The following is a description of a gene set: Mouse Gene Set: GOBP_MONOATOMIC_CATION_TRANSPORT The directed movement of a monoatomic cation, into, out of or within a cell, or between cells, by means of some agent such as a transporter or pore. Monatomic cations (also called simple cations) are positively charged ions consisting of exactly one atom. studied in species Mus musculus, and this is the list of marker genes: Atp6v0a1, Kcnc3, Rem1, Trpv2, Selenon, Kcnn3, Slc22a1, Cacnb2, Tspan13, Steap4, Tspan18, Tmem74, Camk2b, Clca1, Slc25a23, Timd2, Kcnk13, Kcnd2 (NCBI Gene Id 97339), Atp6v1h, Slc45a4 (solute carrier family 45, member 4), Adora2a, Casq2, Atf4, Sphk2, Sik1, Abcb7, Cckar, Afg3l2, Ngf, Slc10a6, Ctss, Atp1b3, Drd3, Oprk1, Nipal4, Tmc2, Slc41a1, Akap9, Pcsk9 (proprotein convertase subtilisin/kexin type 9), Slc30a1, Slc6a8, Adora1, Sumo1 (small ubiquitin-like modifier 1), Heph, Rcvrn, Gas6 (growth arrest specific 6), Gal, Sting1, Dmpk, Letm1, Nkain3, Kcna6, Nkain1, Abcc2, Kcnip4 (Kv channel interacting protein 4), Trem2, Atp2b1, Trpc4, Slc12a5, Gja1, Abl1, Slc5a3, Cyba, Kcnf1, Trpc2, Pdgfrb, Grin2a, Plch1, Slc30a4, Slc6a18, Grm7, Plcb2, Slc39a7, Scara5, Cblif, Ednrb, Slc4a7, Tmco3, Lilra5, P2rx6, Gsto1, Otop2, mt-Nd5, Ubash3b, Cldn16, Slc25a5, Slc6a21, Slc6a11, Atp5mf, Kcnmb2, Tmx1, Atp4b, Slc12a7, Kcnab3, Trpa1, Slc6a7, Scn1a, Ndufa4, Nipal2, Oprd1, Slc6a19, B2m, Flvcr1, Kcnk10, Sestd1, Atp6v1g2, Steap2, Ccl21f, Fgf2, Slc9a9, Scnn1g, Slc47a2, Tmem37, Slc6a4, Asic5, Wnk4, Sec61a1, Gja4, Kcnt2, Kcnj14, Trdn, Casr, Nos1, Rab11b, Slc25a14, Nipal3, Cyc1, Slc10a5, Camk2g, Wfdc6a, Ucp1, P2rx7, Slc38a5, Hcn3, Plcb1, Scn4b, Slc36a3, Tusc3, Tmem63c, mt-Nd4, Akt3, Creb3, Slc12a3, Clec4b1, Atp6v1g1 (ATPase, H+ transporting, lysosomal V1 subunit G1), Ikbkb, Atp6v0b, Tcirg1, Adrb2, Zdhhc13, Adcyap1r1, Atp2b4, Abcb6 (NCBI Gene Id 74104), Large1, Slc17a2, Fxyd5, Hspa9, Cxcl12, Slc36a1, Slc17a6, Scn7a, Atp6ap1, Rhoa, Gck, Lyn, Flvcr2, Drd1, Atp6v1c2, Fkbp1b, Jph3, Kcnk12, Kcnip1 (NCBI Gene Id 72952), Plcl2, Uqcrfs1, 1810037I17Rik, Calm3, Otop1, F2, Pgrmc2, mt-Co1, Slc4a10, Ednra, Usp2, Cacng8, Abcc5, Ffar1, Slc9a4, Slc5a4b, Atp5f1b, Tmem163, Kcnq1, Catsper3, Slc8a2, Ccr5, Agt, Nppa (natriuretic peptide type A), Tmem94, Ccl19-ps5, Pkd1l1, Kcnq2 (potassium voltage-gated channel, subfamily Q, member 2), Ccl5, Grin2d, Atp2c1, Tfr2, Chrng, Kcna7, Tgfb2 (transforming growth factor, beta 2), Atp5mc1, Plcl1, Atp5pb, Kcnj6, Klhl3, Osr1, Trpm1, Slc41a2, Atp6v1a, Mmgt1, Cd19, Chp2, Ank3, Steap3, Cachd1, Selenok, Scnn1a, Catsper1, Slc4a8, Kif5b, Vmp1, Slc8a3, Il4, mt-Co3 (mitochondrially encoded cytochrome c oxidase III), Gnaq, Arrb2, Ace, Jph4, Slc5a4a, Cdkn1b, Ifng, Abcb8 (NCBI Gene Id 74610), Kcne2, Slc6a2, Atp6ap2, Fgf12, Gnb5, Hrc, Cacna1i, Slc39a5, Vamp2, Ppp3cc, Itgav, Gnao1, Slc1a3, Mllt6, Epo, Pdpk1, Surf1, Per1 (period circadian clock 1), Nfatc1, Pkd2 (polycystin 2, transient receptor potential cation channel), Slc23a2, Slc6a13, Scn3b, Cacna1b, Hsd3b6, Pacsin3, Tmco1, Commd9, Atp13a4, Inhca, Slc30a9 (NCBI Gene Id 76440), Kcng3, Cacnb4, Mcu, Micu2, Spg11, Ncs1, Slc25a13, Kcnk6, Cngb3, Nedd4l, Kcnn1, Mcub, Letm2, Kcnj5, Slc4a4, Ptger3, Htr2c, Ahcyl1, Slc39a14, Slc17a1, Atp1a2, Plch2, Tspo, Slc8a1, Fthl17e, Cacna1f, Tmem175, Slc25a28, Slc12a4, Ctnnb1, Ehd3, Dysf, Hamp2, Ptpn22, Dhrs7c, Pkd2l1, Wnt3a, Slc41a3, Htt, Ndufs2, Atp2c2, Romo1, Kcnn4, Rnasek, Gstm7, Abcc9, Kcnc2, Homer3, Nipal1, Slc6a20b (NCBI Gene Id 22599), Coa8, Slc22a4, Plp1, Hamp, Kcne5, Aplnr, Kcnc1, P2rx5, Chrna9, Slc38a11, Cx3cl1, Trpm6, Slc39a9, Lrrc38, Ctns, Slc20a1, Serpine2, Flna, Slc9c1, Cacna2d3, Nalf2, Cox4i2, Alg10b, Kcnk15, Homer1, Kcnma1, Fxn, Ank2, Kcnab2, Lrrc26, Ltf, Scn9a, Inpp5k, Gpr35, Myo1b, Atp5mc3, Vdac1, Cyp27b1, Cacng5, Grp, Hephl1, Hcn4, Calhm1, Rgs9, P2rx4, Nkx2-5, Slc48a1, Lpar3, Cd63, Lime1, Cbarp, Trpv4, Pml, Slc18a3, Mmp9, Kcnv1, Amigo1, Slc39a1, Cacna1e, Slc18b1, Mettl21c, Scnn1b, Trpc5, Slc18a2, Ptpn3, Kcnab1, Bdkrb1 (NCBI Gene Id 12061), Slc5a5, Kcnip3, Saraf, Cnga2, Tmc1, Kcng2, Atp7b, Otop3, Zmpste24, Scn8a, Tmem63b, Slc45a2, Slc25a25, Neto1, Slc30a5, Chrna1, Atp10d, Slc5a7, Plcb3, Slc30a8, Slc9a8, Slc17a7, Rgs4, Gpr39, Rgs7, Fxyd1, Asic3, Ptk2b, Orai1, Slc10a4, Ppp3cb (protein phosphatase 3, catalytic subunit, beta isoform), Orai3, Cngb1, Slc5a8, Tmem38a (NCBI Gene Id 74166), Cacng3, Adra1a, Kcnk18, Panx2, Calcrl, Nalf1, Slc15a1, Atp6v0e, Slc18a1, Stim1, Best1, Cacng4, Plcg2, Ppp3r1, Ramp3, Il6, Slc30a6, Wnk1, Slc5a12, Atp7a, Dspp, Slc24a4, Ndufs4, Nipa1, Slc39a12, Magt1, Slmap, Gcg, Cnksr3, Slc25a37, Ndufv1, Fmr1, Grm6, Commd3, Atp2a1, Slc4a11, Gimap5, Ryr3, Sri, Slc8b1, G6pd2, Slc15a4 (solute carrier family 15, member 4), Cdk2, Crh, Panx3, Scn10a, Prkcb, Cacnb3, Camk2a, Kcnrg, Mfsd4b1, Serpine1, Slc24a3, Atp6v0e2, Snta1, Slc31a1, Myo5a, Piezo1, Fkbp4, Oga, Atp5f1e, Epm2a, Kel, Pdgfb, Nol3, Camk2d, Srl, Micu3, Bhlha15, Ppp3r2, Akap5, Slc30a3, Hcn1, Trpm7, Gnb2, Edn1, Tmem63a, Tmem150c, Slc25a3, Atp1a3, Snx3, Mt3, Slc46a1, Fbxo11, Kcnk2, Kcns3, Cacna1d, Slc11a1, Kcnj8, Gnai2, Stac2, Atp13a3 (NCBI Gene Id 385637), Kcng4, Edn3, Atp12a, Stc1, Npsr1, Ccr1l1, Atp6v0d2, Mcur1, Ndfip1, Slc39a11, Hpn, Slc39a3, Trpv6, Gpm6a, Ucp3, Lrrc55, Ndufs3, Vps4b, Slc1a1, Cox7a1, Cxcl9, Tgfb1, Atp5f1a, Icam1, Psen1, Slc5a9, Capn3, Ccl19-ps4, Ano6, Slc12a2, Slc39a10, Smdt1, Nkain2 (Na+/K+ transporting ATPase interacting 2), Slc4a9, Slc11a2, Kcnj12 (NCBI Gene Id 16515), Atp5mc2, Chrne, Slc45a3, Slc38a3, Kcnj1, P2rx3, Trim27, Kcnq5, Ucn, Slc34a1, Cacna1a, Wfs1, P2rx1, Tcn2 (transcobalamin 2), Ccl21b, Hbp1, Ramp1, Atp5me, Kcnmb3, Slc45a1, Atp6v0d1, Steap1, Dpp10, Slc6a16, Trpm3, Cnga3, Slc6a3, Sfxn1 (sideroflexin 1), Slc39a13, P2ry12, Hpca, Il16, Kcnn2, Cav1, Gjc2, Kcnh2, Cacna1c, Cherp, Slc34a2, Isl1, Ubqln1, Cpox, Il13, Lrp2, Bpifa1, Panx1, Commd1 (NCBI Gene Id 17846), Ahr, mt-Co2, Cxcl11, Slc38a2, P2ry6, mt-Nd3, Cxcl10, Ndufs8, Homer2, Cacng7, Trpm2, Cav3, Cdk5, Slc32a1, Trpv5, Chrnd, Slc39a8, Lcn2, Hoxa3, Itpr2, Bin1, Slc38a4, Maged2, Cxcl1, Ndufa2, Cask, Pkd1, Slc31a2, Agrn, F2r, Smim6, Atp5mg, Akt2, Taco1, Arf1, Cacna1g, Gcm2, Catsper2, Tescl, Gpd1l (glycerol-3-phosphate dehydrogenase 1-like), Mrln, Ccdc51, Scn3a, Atp6v0a4, Ywhae, Bax, Slc39a6, Grin3a, Slc25a12, Cacna2d2, Ppp3ca, Slc22a2, Slc25a4, Prkce, Cacng6, Slc17a8, Ccl19, Hspa2, Ptgs2, Slc9b1, Nipa2, Kcna4, F2rl3, Gramd2a, Slc5a11, Gja5, Grin3b, Plcb4, Kcnv2, Slc6a14, Slc5a2, Actn2, Sco1, Gm5134, Tesc, Coro1a, Pde4d, Trf, Slc38a1, Scn4a, Strit1, Slc40a1, Gp9 (NCBI Gene Id 54368), Meltf, Trpm4, Tmem38b, Ano10, Nfatc3, Cntn1, Eppin, Cacng2 (calcium channel, voltage-dependent, gamma subunit 2), Kcnq4, Piezo2, Chd7, Chrna4, Kcnj9, Atp6v0a2, Trpm5, Orai2, Itpr3, Galr2, Slc34a3, Slc13a1, Lgals3, mt-Atp8, Slc12a6, Ftmt, Kcnj13, Slc13a2, Tfrc, Pln, Nherf1, Kcnh1, Bcl2 (B cell leukemia/lymphoma 2), Dpp6, Ccl21a, mt-Nd6, Slc23a1, Htr2a, Kcnq3, Oxsr1, Abcc8, Zfas1, Nr3c2, Dlg1, Scn5a, Akap7, Scn11a, Slc6a9, Atg5, Grin1, Vip, Stimate, Kcnd3, Thy1, Kcnj2, Gimap3, Ano9, Myb, Itgb1, Xcr1, Slc39a4, Snap25, Wnk2, Prss8, Mllt3, Anxa6, Ryr2, Nsf, Stac3, Slc12a8, Kcnc4, Itgb3, Tmem109, Aqp2, Hcrt (hypocretin), Slc24a1, Atp2b2 (NCBI Gene Id 22426), Slc9a3, Gper1, Hpx, Iscu, Hap1, Asic4, Atp6v1e2, Slc47a1, Atp6v1g3, Cacng1, Slc24a5, Prkd1, Slc16a1, Cacna2d1, Ndufs7, Rep15, Slc22a5, Atp1a1 (NCBI Gene Id 229653), Ccl19-ps6, Crbn, Ndufv2, Rapgef3, Stac, Kcnb2, Sptbn4, Calhm2, Ccr1, Atp1b4, mt-Nd1, Ibtk, Stim2, Atp6v1b2, Pon3, Kcnj16, Kcna1, Atp6v0c, Asic1 (acid-sensing ion channel 1), Slc5a1, Atp1b1, Catsper4, Tmbim6, Kcna2, Atp4a, Trpc3, Dot1l, Ndufa10, Rangrf, Ms4a2, Tlr9, Slc38a7, Ccl19-ps1, Atp5po, Dbi, Cemip, Kcnk16 (potassium channel, subfamily K, member 16), Slc17a4, Phb2, Bpifa5, Slc6a15, Fcrl5, Dmac2l, Bak1, Adcyap1, Cnnm2, Gm13629 (predicted gene 13629), Pik3cg, Fth1, Prss30, Cftr, Dnm1l, Slc10a2, Slc9a7 (NCBI Gene Id 278183), Kcnj15 (NCBI Gene Id 56497), Grin2b, Chrnb2, Pawr, Lhcgr, Chrnb1, Tmem168, Slc6a5, Lck, Diaph1, Kcnh8 (potassium voltage-gated channel, subfamily H (eag-related), member 8), Atp1b2, Pkd1l3, Pik3c2a, Atp5f1d, Atp5f1c, Umod, Ccl12, Akap6, Slc5a6, Atp1a4, Kcnmb4, Drd4, Mcoln1, Dmd, Atp13a5, Cracr2b, Wnk3, Fxyd7, Kcnip2, Ap3d1, Plcg1, Chp1, Nnt, Adrb1, Slc20a2, Ptprc, Plce1, Trpc1, Kcnk5, Egf, Fxyd6, Sgk1, Mcoln2, Ftl1, Kcnj4, Slc36a2, Calm2, Kcns2, Slc39a2, Hcn2, Slc13a3, Plpp4, Kcnk4, Ryr1, Kcnd1, Clcn7, Hif1a, Igf1, Maip1, Trpm8, Slc10a7, Nedd4, Drd2, Htr2b, Kcnu1, Kcna10, Kcns1, Slc5a10, Slc12a9, Mcoln3, Spink1, Casq1, Scn1b, Cnga1, Slc30a10, Cnga4, Slc6a6, Ghitm, Kcng1, Gp5, Cdh23, Kcnj11, Ms4a1, Gp1bb, Slc30a7, Cracr2a, Cacna1s, Hfe, Ywhah (NCBI Gene Id 22629), Grin2c, Efhb, Itpripl1, Kcnh7, Glp1r, Aqp1, Ptpn6, Slco2b1, Micu1, Atp13a2, Hrh1 (histamine receptor H1), Dnm2, Slc12a1, Kcnh3, Wwp2, Ccl19-ps3, Tmem165, Kcnk3, Gp1ba, Ccl21e, Cd84, Kcnk1 (NCBI Gene Id 212682), Slc25a22, Atp6v1b1, Atp2a2, Vdr, Arhgap1, mt-Nd4l, Scn2a, Stc2, Slc9a5, Scn2b, Cltc, Fxyd4, Slc13a5, Calm1, Slc9a6, Psen2, Mchr1, Trpc7, Prnp, Nalcn, Itpr1, Stk39, Ddit3, Mmgt2, mt-Atp6, Cacna2d4, Kcnh6, Kcnh5, Jsrp1, Fxyd2, Atp6v1d, Kcne4, mt-Nd2, Kcnmb1, Guca2b, Fgf13, Cacnb1, G6pdx (glucose-6-phosphate dehydrogenase X-linked), Opa1, Ndufb7, Sln, Ramp2, Ubr3, Jak3, mt-Cytb, Asic2, Uqcrh, Gria2, Bmp4, Tsc1, Atp5pd, Slc25a18, Ccl21d, Trpv3, Mylk, C2cd6, Epb41 (erythrocyte membrane protein band 4.1), Slc10a1, Fhl1, Kcna5 (NCBI Gene Id 213586), Calhm3, Slc9a1, Ero1a, P2rx2, Slc28a3, Cxcr4, Gnas, Ccl8, Atp6v1f, Fxyd3, Slc9a2, Best2, Kcnk7, Kcnj10, Bspry, Slc4a5, Lrrc52, Xcl1, Trpc6, Ahnak, Tpcn1, Slc35g1, Akt1, Chrna7, Asph, Spg7, Slc6a20a, Plcz1, Cnnm4, Mrs2, Hes1, Kcnh4, Ndufs1, Atox1, Slc25a27, Hvcn1, Cacna1h, Ccl3, Slc6a1, Atp6v1c1, Hsd3b2, Nos3, Atp2b3, Grxcr1, Slc29a4, Lmtk2, Slc30a2, Slc9b2, Nipsnap2, Kcna3, Kcnk9, Cd4, Slc22a17, Ucp2, Ppif, Atp2a3, Hsd3b3, Cysltr1, Atp5pf, Kcne1, Agtr1a, Cxcr3, Slc46a3, Fasl, Pirt, Jph2, Kcnj3, Slc24a2, Kcne3, Fgf14 (NCBI Gene Id 14169), Nectin1, Crhr2, Tpcn2, Atp6v1e1, Fkbp1a, Fyn, Atpsckmt, Slc15a2, Kcnt1, Ccn2, Ntsr1, Kcnb1, Snca, Nkain4, Slc6a17, Rnf207, Slc6a12, Trpv1, Cox17, Clcn3